The following is a description of a gene set: from publication Chen Y, Wang X (PMID 31504780) species: Homo sapiens Genes predicted to be targets of miRBase v22 microRNA hsa-miR-1250-5p in miRDB v6.0 with MirTarget v4 prediction scores > 80 (high confidence targets). Human Gene Set: MIR1250_5P, and this is the list of marker genes: NR1I2, CAMSAP1, HOXC6, GAREM2, MARVELD3 (MARVEL domain containing 3), MANBA, DNAJC18 (NCBI Gene Id 202052)